Given this list of marker genes AGO3, CNOT6, PATL2, DHX36, MIR140, PDE12, DND1, MIR1-1, MIR130A, ELAVL1, DCP1B, PAIP1, MIR4286, MIR34B, CNOT2, DCP2, NANOS2, MIR665, MIR373, CAPRIN1, CNOT7, GTPBP1, MIR485, UPF1, NOCT, ZC3H12A, MIR210, MIR19B1, HNRNPU, MIR497 (microRNA 497), ZFP36L2, CNOT8, PLEKHN1, MIR27B, POLR2G, MIR27A, MIR9-1, MIR214, DIS3, PNLDC1, CNOT9 (CCR4-NOT transcription complex subunit 9), TARDBP, TENT4B, CNOT11, AGO2, TENT4A, MIR195, HNRNPD, METTL14, SYNCRIP, MIR100, MIR519D, MIR130B, CSDE1, NANOS3, MIRLET7C, LSM1, MIR206, TNKS1BP1, MIR18A, PIWIL1 (piwi like RNA-mediated gene silencing 1), MIR125B1, MIR302A, CNOT10, MIR200C (NCBI Gene Id 406985), ROCK2, MIR544A, FXR1, MIR30B, YTHDF2, MIR340, MIR329-1, MIR106B, MIRLET7E, MIR885, PUM2, MIR564, MIR106A, CNOT6L, MIR486-1, MIR708, TRIM71, MIR501, RIDA, TUT7, MIR192, ZFP36, MIR142, PRR5L, MOV10, SAMD4B, MIR190B, IGF2BP1, CNOT3, PATL1, MIR20B, NT5C3B, PABPN1L, MIR26B, MIR103B1, ZC3H12D, ALKBH5, DCP1A, ZC3HAV1, CPEB3, MIR302C, MIR517A, MIR663A, MIR211, PIWIL2 (NCBI Gene Id 55124), MIR96, MIR365A, YBX1, MIR125A, MIR128-1, MIRLET7A1, RBM24, MIR519A1, TTC5, MIR181C, TUT4, MLH1, MIR19A, GTSF1, MIR151A, MIR543, DCPS, MIR193A, PABPC1, YTHDF3, RC3H1 (NCBI Gene Id 149041), MIR135B, MIR185, METTL16, NANOS1, MIR181A2, MIR133A1, MIR191, MIR23A, MIR146A, MIR223, BTG2, QKI (QKI, KH domain containing RNA binding), MIR483, METTL3, CNOT4, RC3H2, MIR491, MIR181D, MIR424, MIR423, MIR517C, CELF1, ZFP36L1, MIR93, GIGYF2, MIR337, YTHDF1, MEX3D, PAN3, AGO4, PARN, MIR149, MIR29B1, MIRLET7B, ROCK1, MIR342, MIR520C, MIR137, MIR326, MIR181B1, PAN2, MIR199B, AGO1, MIR212, MIR655, CNOT1, MIR495, SAMD4A, EIF4ENIF1, MIR98, PUM1, FXR2, TNRC6B, MIR20A, MIR24-1, FTO, MIR145, KHSRP, MIR200B, MIR203A, TNRC6C, PNPT1, TNRC6A, MIR204, DHX9, TOB1, DIS3L2, MIR320A, MIR608, MIR562, MIR625 (NCBI Gene Id 693210), here is a description of the gene set: species: Homo sapiens Human Gene Set: GOBP_POSITIVE_REGULATION_OF_MRNA_CATABOLIC_PROCESS Any process that increases the rate, frequency, or extent of a mRNA catabolic process, the chemical reactions and pathways resulting in the breakdown of RNA, ribonucleic acid, one of the two main type of nucleic acid, consisting of a long, unbranched macromolecule formed from ribonucleotides joined in 3',5'-phosphodiester linkage.